Given this list of marker genes Fth1, Sc5d, Sqstm1, Aifm2, Nfe2l2, Slc7a11, Hmox1, Nqo1, Gpx4, here is a description of the gene set: Mouse Gene Set: GOBP_NEGATIVE_REGULATION_OF_FERROPTOSIS species: Mus musculus Any process that stops, prevents, or reduces the frequency, rate or extent of ferroptosis.